Given this list of marker genes INS, DHFR, SCN9A, DHDDS, TRAPPC9, GRM7, PIGT, ABCC8, ARX, CLCN2, TRIT1, OPHN1, IER3IP1, STX1B, SLC25A15, MT-TQ, ACBD6, CDKL5, SCN1B, GABRB3, MFSD8, MT-TP, TSEN54, NDE1, DNM1, MT-ATP6, BRAT1, PIGA, AP2M1, TSEN34, GNAO1, MBOAT7, SMC1A, KCNT2, EFHC1, GRN, PCDH12, KCNA1, ELOVL4, GABRD, TSEN2, ADGRG1, GALC, GABRA1, NSD1, MT-ND6, MT-TH, MT-ND3, DPM2, PLAGL1, ADGRV1, BTD, KCNQ3, HYMAI, CUX2, DYRK1A, PCDH19, MT-ND1, GBA1, CILK1 (NCBI Gene Id 51541), NTNG1, KNSTRN, ALDH5A1, MT-TW, MT-TF, NEXMIF, GPHN, CHD2, LNPK, HACE1, NEUROD2, SLC6A1, CPLX1, CARS2, PIGH, BCKDK, SDHB, GRIN1, GAMT, MAPK10, SLC32A1, STXBP1, KCNJ11, DNM1L, DMXL2, LMNB2, MECP2, DPM1, PIGQ, DPAGT1, HCN1, PIK3CD, SDHAF1, MT-ND2, GABRG2, NDUFA1 (NCBI Gene Id 4694), SLC2A1, SCN2A, ALDH7A1 (aldehyde dehydrogenase 7 family member A1), CACNA1A, PTEN, CLN8, STAT3, SLC12A5, MT-TS2, CASK, PHGDH, MT-TK (NCBI Gene Id 4566), SYNGAP1, NHLRC1, GCK, MT-ND5, PSAP, GABBR2, PNKP, MT-TI, SDHA, NGLY1, PIGP, BUB1B, TRIM8, TBC1D24, SDHD, SEPSECS, TANGO2, EPM2A, PTRH2, KCNQ2, SCN1A, SLC25A22, MT-TL1, PRRT2, MT-RNR1, NUS1, AFG3L2, KCTD7, FGF13, MT-ND4, AFG2A, ASAH1, TSEN15, PRDM8, SAMD12, MTHFR, SLC38A3, GLB1, PRICKLE1, MT-TV, APC2 (NCBI Gene Id 10297), SCN8A, SIK1, NEU1, PDX1, PAFAH1B1, SMS, here is a description of the gene set: A generalized myoclonic seizure is a type of generalized motor seizure characterized by bilateral, sudden, brief (<100 ms) involuntary single or multiple contraction of muscles or muscle groups of variable topography (axial, proximal limb, distal). Myoclonus is less regularly repetitive and less sustained than is clonus. species: Homo sapiens Generalized myoclonic seizure Human Gene Set: HP_GENERALIZED_MYOCLONIC_SEIZURE